The following is a description of a gene set: Human Gene Set: GOMF_UBIQUITIN_LIKE_PROTEIN_CONJUGATING_ENZYME_ACTIVITY studied in species Homo sapiens Isoenergetic transfer of a ubiquitin-like protein (ULP) from one protein to another molecule, usually another protein, via the reaction X-SCP + Y = Y-SCP + X, where both the X-SCP and Y-SCP linkages are thioester bonds between the C-terminal amino acid of SCP and a sulfhydryl side group of a cysteine residue., and this is the list of marker genes: UBE2N, CDC34, AKTIP, UBE2L6, UBE2A, UBE2L5, UBE2Q2, UBE2M, UBE2D4, UBE2W, UBE2J2 (ubiquitin conjugating enzyme E2 J2), UBE2T, UBE2E2, UBE2Q1, UFC1, UBE2G1, ATG3, ATG10, UBE2Z, UBE2S, UBE2G2, UBE2NL, UBE2O, UBE2E1, UBE2V1 (ubiquitin conjugating enzyme E2 V1), TAF1, UBE2U, UBE2D3 (NCBI Gene Id 7323), UBE2D2, UBE2L3, UBE2R2, UBE2B, UBE2H, UBE2F, UBE2D1, UBE2I, UBE2J1, UBE2E3, UBE2K, UBE2C, UBE2QL1, BIRC6